The following is a description of a gene set: species: Homo sapiens An abnormality of the renal pelvis. Abnormal renal pelvis morphology Human Gene Set: HP_ABNORMAL_RENAL_PELVIS_MORPHOLOGY, and this is the list of marker genes: RECQL4, DYNC2I1, BBS1 (NCBI Gene Id 79702), TRIM28, ATRX, DDX6, BRAF, NPHP1, FOCAD, HDAC4, PEX5, MIA3, RNU4ATAC, POLE, GPC4, COG7, BBS12, HSPG2, BRF1, RORA, DYNC2H1, BBIP1, FGF13 (NCBI Gene Id 730528), DHCR7, WBP4, KCTD1, CDC42BPB, POU6F2, MKS1, ITGA6, CTLA4, MAP3K7, CHST14, ATN1, FH, MRAS, PEX14, G6PC3, CHRM3, CCNQ, BCKDK (branched chain keto acid dehydrogenase kinase), CREBBP, GPC3, PGAP2, NCAPG2, PIGL, EN1, TBC1D24, OFD1, TBX18, ERCC6, BNC2, DYNC2I2, PIGV, LAMA3, GRIA3, PI4KA, ARPC4, SHH, SOS2 (NCBI Gene Id 96829), CFAP418, KRAS, GEMIN4, KAT6A, PEX10, RRAS, CEP19, BBS7, ZMYM3, ARID1B, IPO8, MAP2K2, DDB1, IFT80, PEX19, KANSL1, TAPT1, UBR1, KDM6A, PEX12, USP9X, IARS1, PEX11B, TBX1, COL18A1, FOXF1, BBS9, LZTR1, TBX15, SPEN, CPT2, NRAS, ITGB4, TRIM32, B3GLCT, ERBB3, ZFX (zinc finger protein X-linked), MMP23B, LMNB1, PEX6, PIGY, FAM20C, IFT56, RASA2, TOGARAM1, TASP1, HYLS1, KIAA0753, MASP1, SCAPER, SDCCAG8, GREB1L, HOXD13, APC, DIS3L2, OTUD5, CENPF, SPRED2, POLR1A, RBM10, GATA3, PIGW, WASHC5, H19, HLA-DPB1, PIGO, BBS10, MBTPS2, PAX7, RAB18, PRKCZ, TBC1D20, RAD51C, POR, KMT2D, RERE, BBS5, XDH, CD81, WLS, CHRNA3, NSDHL, SETBP1, WT1, PPP3CA, EBP (NCBI Gene Id 139151), NBN, COG1, NSUN2, EP300, RAB3GAP1, DLK1, TBCK, SOS1, FLNA, ATP6V1B2, PRTN3, SCLT1, KCNAB2, B4GAT1, WDPCP, NDUFAF3 (NADH:ubiquinone oxidoreductase complex assembly factor 3), NXN, PLEC, RBM8A, PEX3, FGFR1, LMOD1, NAA10, RAB23, MID1, CTNNB1, LTBP4, HNRNPK, PIGN, NRIP1, UBE4B, TP63, EHMT1, STRA6, FLI1, DSE, GNB1, ARNT2, LRIG2, SCARF2, WNT5A, PORCN, FGF10, RFX7, IFT74, BCOR, GLI3, ARL6, RTL1, DVL1, KAT6B, PEX13, PLD1 (NCBI Gene Id 5337), NF1, PIEZO2, MED11, ZIC3, IFT172, ERI1, CCBE1, ACTG2, STX5, PEX2, CDC42, RAF1, MEG3, FGFR3, SPINK5, ZBTB18, SLC6A17, DLG5, DPYSL5, ERCC8, MYOD1, GABRD, CASZ1, PGM1, REST, PTPN11, SPART, RAB3GAP2, B3GALT6, SEMA3E, RRAS2, MYMX, CCDC22, PGAP3, MYCN, PRDM16, POLR3A, B9D1, SCAF4, PTPN22, PEX1, TFAP2A, PEX26, CDKN1C, CA2, SRCAP, SIX1, MKKS, RIT1, CLCN3, ACTB, EYA1, YY1, ACTG1, PEX16, TTC8, HPSE2, CAMK2A, MYMK, TRRAP, SOX9, LZTFL1 (NCBI Gene Id 54585), LAMC2, CHD7, HLA-DPA1, WDR35, BBS4, PIGA, MYL9, NFIA, TRIP13, LAMB3, NIPBL, FBXL4, DYRK1A, BBS2, MED12, PDPN, LUZP1, SALL4, IFT27, CRTAP, FGFR2 (NCBI Gene Id 2263), CBL, FANCB, MAP2K1, VPS35L, APC2 (APC regulator of WNT signaling pathway 2), SOX17, DBR1, ZMYM2, ALG9, BAP1, SKI, ATP7A (NCBI Gene Id 613259), MED25, ROR2, SIX5, ZEB2, WFS1, CEP290, BRCA2, ARL3, NSD1 (NCBI Gene Id 6797), LIG4